The following is a description of a gene set: studied in species Homo sapiens The regrowth of a lost or destroyed animal organ. Human Gene Set: GOBP_ANIMAL_ORGAN_REGENERATION, and this is the list of marker genes: BAAT, EZH2 (enhancer of zeste 2 polycomb repressive complex 2 subunit), IHH, IGF2R, SULF2, CAD, RPS15, AURKA, IL10, HSPG2, PTPRU, GAS6, PNPT1, UPF2, PCNA, GUCD1, PDX1, PRMT5, LPIN1, NOTCH1, CXCL12, UCP2, TNF, GSTP1, SRSF5, MED1, BAK1, SRSF1, CCND1, F7, CLDN1, IL6, CPT1A, ATIC, GATA1 (GATA binding protein 1), ANGPT2, CCNA2, SLC7A5, MT-CYB, LCP1, PTCH1 (patched 1), CSNK2A2, CEBPA, WNT1, TGFBR3, NR0B2 (nuclear receptor subfamily 0 group B member 2), RAP1A, CEBPB (NCBI Gene Id 90277), TOP1, TGFB1, GLI1, VTN, FLT3